The following is a description of a gene set: from publication Chen Y, Wang X (PMID 31504780) studied in species Homo sapiens Human Gene Set: MIR509_3_5P Genes predicted to be targets of miRBase v22 microRNA hsa-miR-509-3-5p in miRDB v6.0 with MirTarget v4 prediction scores > 80 (high confidence targets)., and this is the list of marker genes: SLC25A38, TP53TG3C, COL6A6, G6PC1, ACBD3, WAPL, SYNGR2, SLC38A9, SHROOM1, NFXL1, SLC9A7, PSTPIP2, SNX27, EIF4E2, NOS1, MXRA5, WDR82, EHD4, MGAT4A, AP3M1, ANLN, ESRRG, FAM168B, RAB11A, TMEM209, TP53TG3B, PICALM, PROX1, AGFG1 (ArfGAP with FG repeats 1), TNPO1, ACSL6, GARIN6, RAB37, ARF6, HYCC2, ELP3, E2F7, CLSPN, RETREG1, CDC14A, TIAM2, NUP35, GPR85 (G protein-coupled receptor 85), FGF2, CHRNE, KIF5C, SINHCAF, PTPRZ1, CAMTA1, C5orf24 (NCBI Gene Id 134553), HACD3, HSPA9, OGFRL1, CALD1, GMFB, SCAMP1, OGG1, CKLF, BCL11A, SPOPL, PAFAH2, NHEJ1, TOGARAM1, KHDC4, FIGN, GALC, IGF1R, RAP2C, ATP9B, DCLK1, GFOD1, DISC1, SLC1A1, EPHA6, SLC25A5, AFF3, ACLY, SERTAD2, RNF139, NUDT7, WNK3, RHOT1, GOLGA1 (NCBI Gene Id 2800), CAMK2D, DENND6A, PSIP1, EIF5B, MTMR8, NDN, TRAPPC2, ZFAND5, LILRB1, LDB3, OCM2, POGLUT2, GID8, ELOC, GATB, CELA1 (NCBI Gene Id 1990), ZHX1, NLGN1, SMC2, EZH2, TMEM26, ATXN7, PIEZO2, IPO8, GTF2IRD2, MPC1, MED13L, PGRMC1, TARDBP, POLR3F, SYN2, TRAK1, CTNNB1, ANKMY2, GTF2IRD2B, TENM1, HNF1B, TET1, EIF1B, SNED1, BTG1, ZPLD1, G3BP2, EPB41 (erythrocyte membrane protein band 4.1), CCNJ, CCSER2, IQCH (NCBI Gene Id 64799), SLC2A10, PPM1F, WDFY1, TDG, PIP4K2B, ZNF423, MBOAT2, RNGTT, NES, TP53TG3, CSTF2, KIAA0232, MED28, CORO1C (NCBI Gene Id 23603), CD200R1, NFAT5, GPALPP1, CSMD2, INO80D, SLC38A2, OCM, JARID2, TP53TG3D, ANKRD50, P2RY10, KDM4A (NCBI Gene Id 9682), GPM6A, NCAM1, ATAD2B, SYNJ2BP, IP6K3, CIMIP6, TNFRSF19, USP15, ATP11C, DOCK3, SHISA9, RTKN2